The following is a description of a gene set: Regulation of complement cascade, CFHR. Pathway ID: N01504. Pathway type: Reference. Pathway class: nt06513 Complement cascade. studied in species Homo sapiens Human Gene Set: KEGG_MEDICUS_REFERENCE_REGULATION_OF_COMPLEMENT_CASCADE_CFHR Pathway Definition from KEGG: CFHR -| CFH, and this is the list of marker genes: CFHR4, CFHR2, CFHR1, CFHR3, CFHR5, CFH